The following is a description of a gene set: Reactome Pathway: FLT3 signaling through SRC family kinases studied in species Mus musculus electronically inferred by orthology from the curated human pathway part of: FLT3 Signaling This event has been computationally inferred from an event that has been demonstrated in another species.<p>The inference is based on the homology mapping from PANTHER. Briefly, reactions for which all involved PhysicalEntities (in input, output and catalyst) have a mapped orthologue/paralogue (for complexes at least 75% of components must have a mapping) are inferred to the other species., and this is the list of marker genes: Flt3l, Lck, Syk